Given this list of marker genes RHEB, HRAS (NCBI Gene Id 338029), SOS1, TGFA, AKT2, GRB2, RPTOR, EREG, JAK1, PTEN, SOS2, JAK3, AKT1, TYK2, BTC, STAT3, NRAS, JAK2, TSC1, RAF1, EGF, TSC2, PDK1, MTOR, KRAS, AKT3, here is a description of the gene set: Human Gene Set: WP_TYROSINE_KINASE_INHIBITORS_IN_GLIOBLASTOMA Tyrosine kinase inhibitors in glioblastoma species: Homo sapiens